Given this list of marker genes Smad3, Foxo4, here is a description of the gene set: This event has been computationally inferred from an event that has been demonstrated in another species.<p>The inference is based on the homology mapping from PANTHER. Briefly, reactions for which all involved PhysicalEntities (in input, output and catalyst) have a mapped orthologue/paralogue (for complexes at least 75% of components must have a mapping) are inferred to the other species. Reactome Pathway: FOXO-mediated transcription of cell cycle genes electronically inferred by orthology from the curated human pathway part of: FOXO-mediated transcription species: Mus musculus